The following is a description of a gene set: Mouse Gene Set: GOBP_INTRACELLULAR_TRIGLYCERIDE_HOMEOSTASIS studied in species Mus musculus A homeostatic process involved in the maintenance of a steady state level of triglyceride within a cell., and this is the list of marker genes: Nr1h4, Slc25a27, Xbp1, C1qtnf3, Sirt1, Ldah, Pnpla2, Fundc2b, Dgat2, Fundc2, Fitm2